Given this list of marker genes CALM3, TRIM25, AP2M1, MFAP5, VAMP2, RHOA, HNRNPM, PTGDS, TAC1, MAP4K3, TLK1, PHC2, HSPA5, DNMT1, here is a description of the gene set: species: Mus musculus Genes up-regulated in the brain cortex of mice that were exposed to an enriched learning environment for one day. An enriched environment is known to promote structural changes in the brain and to enhance learning and memory performance in rodents. To better understand the molecular mechanisms underlying these experience-dependent cognitive changes, we have used high-density oligonucleotide microarrays to analyze gene expression in the brain. Expression of a large number of genes changes in response to enrichment training, many of which can be linked to neuronal structure, synaptic plasticity, and transmission. A number of these genes may play important roles in modulating learning and memory capacity. Human Gene Set: RAMPON_ENRICHED_LEARNING_ENVIRONMENT_EARLY_UP from publication Rampon C, Jiang CH, Dong H, Tang YP, Lockhart DJ, Schultz PG, Tsien JZ, Hu Y (PMID 11070096)